Given this list of marker genes Gm29083, 9130204K15Rik, Ifi211, Myh9, Gm25582, Smad3, Ark2c, Mpzl1, Ubald2, Mtus1, Ehbp1, Gm6822, Gas7, Sec61bl, Gm17501, Cited2, Junos, Fgf7, Ltbp1, Mir199a-2, Gm12415, Gm4876, Gm28818, Gm10484, Cp, Ptpn22, Mbnl1, Pigt, Mannr (Mecom adjacent non-protein coding RNA), Abl2, Adamtsl4 (ADAMTS-like 4), Emp1 (epithelial membrane protein 1), Vgll4, Met, Fam180a, Mogat1, Zfp365, Gm12518, Irag2, 5430435K18Rik, Tns1, Gm13470, Gm15764, Atosa, Gm4861, Gm15335, Dnm3os, B530045E10Rik, 1700123M08Rik (RIKEN cDNA 1700123M08 gene), here is a description of the gene set: from publication Yevshin I, Sharipov R, Kolmykov S, Kondrakhin Y, Kolpakov F (PMID 30445619) Mouse Gene Set: DLX6_TARGET_GENES studied in species Mus musculus Genes containing one or more binding sites for (Dlx6) in their promoter regions (TSS -1000,+100 bp) as identified by GTRD version 20.06 ChIP-seq harmonization.